Given this list of marker genes GABRG3, GABRA3, GABRA5, GABRE, GABRA2, GABRA6, GABRG2, GABRA1, TSPO, GABRG1, GABRA4, here is a description of the gene set: Combining with benzodiazepines, a class of drugs with hypnotic, anxiolytic, anticonvulsive, amnestic and myorelaxant properties, to initiate a change in cell activity. Human Gene Set: GOMF_BENZODIAZEPINE_RECEPTOR_ACTIVITY studied in species Homo sapiens